Given this list of marker genes Txnl1, Stam, Epha2, Pak3, Pik3r2, Wwp2 (NCBI Gene Id 66894), Cdc42, Wdr6, Depdc1b, Rhou, Arhgef7, Vangl1, Pak4, Grb2, here is a description of the gene set: Reactome Pathway: RHOU GTPase cycle This event has been computationally inferred from an event that has been demonstrated in another species.<p>The inference is based on the homology mapping from PANTHER. Briefly, reactions for which all involved PhysicalEntities (in input, output and catalyst) have a mapped orthologue/paralogue (for complexes at least 75% of components must have a mapping) are inferred to the other species. species: Mus musculus electronically inferred by orthology from the curated human pathway part of: RHO GTPase cycle